The following is a description of a gene set: studied in species Mus musculus Mouse Gene Set: GOBP_POSITIVE_REGULATION_OF_MICROTUBULE_DEPOLYMERIZATION Any process that activates or increases the frequency, rate or extent of microtubule depolymerization., and this is the list of marker genes: Trpv4, Katnb1, Stmn2, Aurkb, Spast, Htr1a